The following is a description of a gene set: studied in species Homo sapiens from publication Chen Y, Wang X (PMID 31504780) Genes predicted to be targets of miRBase v22 microRNA hsa-miR-31-5p in miRDB v6.0 with MirTarget v4 prediction scores > 80 (high confidence targets). Human Gene Set: MIR31_5P, and this is the list of marker genes: GLT6D1, CAMK2D, AK4, ZBTB20, FGF7, STAU2, SEMA6D, ACAA2, SLC6A6, GCH1, TNFRSF9, FNDC5, SLC2A4, IGSF11, FHIP2B, FAM53B, TYW5, MAPKAPK2, WDR5, NSF, NR5A2 (nuclear receptor subfamily 5 group A member 2), LATS2, ZIK1, DTD1, PSMB11, TNS1, TENM4, PRKAA2, MFSD14A, YWHAE, PPP1R9A (protein phosphatase 1 regulatory subunit 9A), RITA1, FOXD4L3, GXYLT1, PCDH8, DUSP7, DMD, TFRC, KHDRBS3 (NCBI Gene Id 10656), VPS26B, RHOBTB1, MINAR1, DCBLD2, TTF2, NUMB, MIGA1, ZNF74, CYREN, RIMS3, TMEM145, MUC21, TMPRSS11F, PC, PRKCE, SATB2, ELAVL1, ODAPH, HIF1AN, HTRA1 (NCBI Gene Id 5654), FOXD4L5, CLOCK, KRT6A, RTL9, SH2D1A, HSD17B6, RNF144B, TBXA2R, ATF6, PARP1, PRKCB, ADAMTS1, VAPB, TMEM43, TBX19, PTPN14, LBH, STARD13, PAX9, ATP13A3, KCTD21, TSGA10, VPS53 (VPS53 subunit of GARP complex), JAZF1, MAP1B, SLC1A2, SEC24A, CLASP2, UACA, PDZD4, TACC1, ZNF512, CIAPIN1, PEX5, OXSR1, NOS1, SMUG1 (NCBI Gene Id 23583), KIAA1549L, MTCL2, ATL2, PIK3C2A, HOMER1, TMEM74, UBXN10, ASCC1, NUFIP2, CRYBG3 (NCBI Gene Id 131544), TESMIN, ARHGEF2, FLOT1, PRKAR2A, EGLN3, STK40, SH3BGRL2, MGAT1, AHCYL1, LYN (LYN proto-oncogene, Src family tyrosine kinase), POU2F1, CEP85L, HLA-A, MAGEA1, SGMS1, VEZT, FOXD4, GPR183, RREB1, AHSA2P, C2orf49, RSBN1, C1orf74, DENND4B, CDC23, VAV3 (NCBI Gene Id 10451), MAGEA12, KCTD20, CSMD1, PAX5, ZNHIT6, SYDE2, NUP153, FOXD4L6, BACH2, PTGFRN, IL34, CCAR2, IGSF3, ATP11C, CALR, FOXD4L1, IDE, ZFP36L1